Given this list of marker genes Ugcg, Stx2, Dmkn, Stx4a, Hdac3, Psap, Mafb, here is a description of the gene set: Mouse Gene Set: GOBP_CORNIFIED_ENVELOPE_ASSEMBLY species: Mus musculus The aggregation, arrangement and bonding together of a set of components to form a cornified envelope.